The following is a description of a gene set: Catalysis of the transfer of an N-acetylgalactosaminyl residue from UDP-N-acetyl-galactosamine to an oligosaccharide. Mouse Gene Set: GOMF_ACETYLGALACTOSAMINYLTRANSFERASE_ACTIVITY species: Mus musculus, and this is the list of marker genes: Chpf, Csgalnact2, Galnt6, B3galnt1, Gbgt1, Galnt3, Galnt2, Galnt7, B4galnt3, Galnt1, Chpf2, Csgalnact1, Galnt16 (NCBI Gene Id 70504), Galnt14, Galnt17, Galnt18, B4galnt1, Galnt10, B4galnt2, Galntl6, Galnt15, Galnt12, Galnt11, Galnt4, Galnt13, Galnt5, Chsy3, B3galnt2, Galnt9, Extl2, Chsy1, B4galnt4, Abo